Given this list of marker genes SNX6, MAD2L2, PAK2, ERRFI1, SOCS4, YWHAG, CDKN2A, TAF7, APC (NCBI Gene Id 324), TSG101, ADAR, DEFB114, CHMP6, PTPRC, CDKN1C, ZFYVE28, RGS14, RTRAF, WARS1, DUSP1, APOE, RPL23, EIF4A2, PDCD4, STK38, GSKIP, MYCNOS, PTPN1, CEP43, MIDN, MAPK8IP1, CORO1C, AIDA, CDK5RAP1, INCA1 (inhibitor of CDK, cyclin A1 interacting protein 1), HNRNPU, CEP85, ABL1, DTX3L, BANF1, MVP, DNAJA1, GCKR, CDKN1A, NPM1, ITGB1BP1, CD300A, PRKCH, PTPRJ, PKIA, RB1, AKT1S1, ADARB1 (NCBI Gene Id 104), PPIA, ZGPAT, SFN, NPPA, RPS7, RPL11, HEG1, LATS2, MACROH2A1, VPS25, DBNDD2, CEACAM1, CDKN1B, LATS1, GSK3A, PRKN, RPL5, XRCC1, CHP1, THY1, USP44, SOCS5, PTK6, GPRC5A (NCBI Gene Id 9052), SRCIN1, TRIM27, ZFP36, ADIPOQ, TFAP4, LYN, TARBP2, MAD2L1, FBXO5, SERPINB3, PPM1E, AGT, ACP4, DEPTOR (NCBI Gene Id 64798), CDK5RAP3, NPRL2, GADD45A, PAQR3, GSK3B, HIPK3, RASIP1, PTPN22, DUSP7, PYCARD, MEN1, PRDX3, here is a description of the gene set: Human Gene Set: GOBP_NEGATIVE_REGULATION_OF_TRANSFERASE_ACTIVITY studied in species Homo sapiens Any process that stops or reduces the rate of transferase activity, the catalysis of the transfer of a group, e.g. a methyl group, glycosyl group, acyl group, phosphorus-containing, or other groups, from a donor compound to an acceptor.